Given this list of marker genes SRGAP3, AFG1L, SH3BGRL, ITGB2, ATOSA, SNX32 (NCBI Gene Id 254122), ZBTB38, GAS7, ERN1, KCNJ8, RAC3 (NCBI Gene Id 5881), NEK6, GDPD5 (glycerophosphodiester phosphodiesterase domain containing 5), XRN1, PKD2, PTPRE, SCYL3, STIMATE, BCAS3, FYN, MAPKBP1, GPR155, UBR3, FAM53B, GFOD1, TTC39C, TRAF5, DCAF5, ARAP2, GPR137B (G protein-coupled receptor 137B), RABGAP1L, TYK2, RFT1, IL15RA, SULF2, CHRNE, ZDHHC15, SLC35B3, SLC28A2, ACO1, GZMA, FRYL, RALGAPB, RNF216 (NCBI Gene Id 54476), KIF13B, PMP2, SEMA6D, AS3MT, LRBA, NOD1, TMTC3, LRRK1, ADAMTS6, ENTPD1, XCL1, PTPN13, HIP1, CX3CR1, UPF3B, SELENON, OTUD7B, IL10RA (NCBI Gene Id 3587), ST3GAL4, KDM7A, SLC16A6, LCOR, MFSD8, FBXL17, SIRT7, THEMIS, BCL2L1, PTP4A2, SAMD3, TAFA3, ASB2, ATP2A3, PIK3AP1, SLAMF7, LPCAT4 (NCBI Gene Id 91188), CMKLR1, VAMP3, HPSE, TMEM37, SAMSN1, ZEB2, CYP17A1, SERPINA9, RAD54L2, SYTL2, NKG7, PTK2B, CRIM1, DOP1B, NCOA1, SIK3, DCUN1D3, CDC42EP1, CARNS1 (NCBI Gene Id 57571), VSIG10L, SLC25A53, PLCB3, TBL1XR1, MKRN1, RAPGEF1, DAB2IP, GPM6B, MED12L, JADE2, PPP3CA, MCTP2, PPP1R12A, ITGA4, RASGEF1A, CTSD (NCBI Gene Id 196214), STXBP5, GSAP, CRY2, PTPN11, HACE1, TNFSF13B, NBEAL2, ARNT2, AJUBA, CD22, TMEM104, PPM1J, CHST15, APAF1, PDE7A, TMEM163, B3GNT2, PLAAT3, SOAT2, LMBR1L, SLC38A9, DOCK5, ICAM1, MXD4, ACOXL, F2R, IKZF3, WDR81, LAX1, YPEL5, KLRD1, CSF1, DGKH, FBXW7 (F-box and WD repeat domain containing 7), CD274, KCNK6, LPIN2, MIR140, PITPNM1, IL18RAP, KLF3, DCLK1, RGS3, DDX6, MINDY3, CHST2, PREX1, SMAD3, CDC20B, RNF43, PTGER4, RXRA, APLP1, PLXDC2, SNTB2, IMPACT, TGM7, PHLPP2, TTC7B, POGK, ASRGL1, here is a description of the gene set: IFNs are highly pleiotropic cytokines also endowed with marked anti-angiogenic activity. In this study, the mRNA expression profiles of endothelial cells (EC) exposed in vitro to IFN-alpha, IFN-beta, or IFN-gamma were determined. We found that in HUVEC as well as in other EC types genes were upregulated (>2-fold increase) by IFNs, including genes involved in the host response to RNA viruses, inflammation, and apoptosis. Interestingly, genes showed a >5-fold higher induction by IFN-alpha in EC compared to human fibroblasts; among them, the gene encoding the angiostatic chemokine CXCL11 was selectively induced by IFN-alpha in EC along with other genes associated with angiogenesis regulation, including CXCL10, TRAIL, and guanylate binding protein 1 (GBP-1). These transcriptional changes were confirmed and extended by quantitative PCR analysis and ELISA; whereas IFN-alpha and IFN-beta exerted virtually identical effects on transcriptome modulation, a differential gene regulation by type I and type II IFN emerged, especially as far as quantitative aspects were concerned. In vivo, IFN-alpha-producing tumors over-expressed murine CXCL10-11, GBP-1 and TRAIL, with evidence of CXCL11 production by tumor-associated EC. Overall, these findings improve our understanding of the anti-angiogenic effects of IFNs by showing that these cytokines trigger an anti-angiogenic transcriptional program in EC. Moreover, we suggest that quantitative differences in the magnitude of the transcriptional activation of IFNresponsive genes could form the basis for cell-specific transcriptional signatures. Genes up-regulated in fibroblasts: interferon alpha versus IFNG. from publication Indraccolo S, Pfeffer U, Minuzzo S, Esposito G, Roni V, Mandruzzato S, Ferrari N, Anfosso L, Dell'Eva R, Noonan DM, Chieco-Bianchi L, Albini A, Amadori A (PMID 17202376) studied in species Homo sapiens Human Gene Set: GSE3920_IFNA_VS_IFNG_TREATED_FIBROBLAST_UP